The following is a description of a gene set: Abnormal blood transition element cation concentration Human Gene Set: HP_ABNORMAL_BLOOD_TRANSITION_ELEMENT_CATION_CONCENTRATION An abnormality of the homeostasis (concentration) of transition element cation. studied in species Homo sapiens, and this is the list of marker genes: TFR2 (transferrin receptor 2), ATP7A, ATP6V0A2, MMP1, STEAP3, SLC39A8, PSTPIP1, CP, SLC39A4, PKLR, SLC31A1, ATP7B, STAB1, CARD9, SLC11A2, BCS1L, SLC25A38, ATP6AP1, FTL, SKIC3, AFG2A, FTH1, SLC33A1, ABCD3, FOXP1, SLC30A10, IARS1, BMP6, KIF23, HFE, SKIC2, BMP2, HBB, TMEM199, SLC7A7, AP1B1, RACGAP1, HJV, COG2, TMPRSS6, HAMP, SCO2, ALAS2, COL7A1, PIGA, SLC40A1, AP1S1, SLC30A2, TRNT1